Given this list of marker genes GNAZ, ADGRV1, RGS2, GNAI1, GRM7, here is a description of the gene set: Human Gene Set: GOMF_ADENYLATE_CYCLASE_INHIBITOR_ACTIVITY Binds to and decreases the activity of adenylate cyclase. species: Homo sapiens